The following is a description of a gene set: Human Gene Set: GOBP_POINTED_END_ACTIN_FILAMENT_CAPPING The binding of a protein or protein complex to the pointed (or minus) end of an actin filament, thus preventing the addition, exchange or removal of further actin subunits. studied in species Homo sapiens, and this is the list of marker genes: LMOD1, LMOD3, TMOD3, LMOD2, TMOD1, TMOD4, TMOD2